Given this list of marker genes CYP1B1, F12, ADA2, MYOC, SERPINC1, LOXL1, EFEMP1 (EGF containing fibulin extracellular matrix protein 1), here is a description of the gene set: Human Gene Set: HP_RETINAL_VEIN_OCCLUSION Retinal vein occlusion Blockage of the retinal vein. studied in species Homo sapiens